Given this list of marker genes JAG1, NEURL1B, PSEN1, UBA52, EGF, DLL4, PSEN2, PSENEN, APH1A, JAG2, YBX1, UBC, MIB1, NEURL1, ADAM10, TACC3, DLL1, RPS27A, APH1B, UBB, NCSTN, WWP2, EGFR, MIB2 (NCBI Gene Id 142678), NOTCH3, here is a description of the gene set: studied in species Homo sapiens NOTCH3 Activation and Transmission of Signal to the Nucleus Human Gene Set: REACTOME_NOTCH3_ACTIVATION_AND_TRANSMISSION_OF_SIGNAL_TO_THE_NUCLEUS